The following is a description of a gene set: All-trans retinoic acid (RA) induces transforming growth factor beta (TGF-beta)-dependent autocrine growth of mouse embryonic fibroblasts (MEFs). We have used chromatin immunoprecipitation to map 354 RA receptor (RAR) binding loci in MEFs, most of which were similarly occupied by the RAR alpha and RAR gamma receptors. Only a subset of the genes associated with these loci are regulated by RA, among which are several critical components of the TGF-beta pathway. We also show RAR binding to a novel series of target genes involved in cell cycle regulation, transformation, and metastasis, suggesting new pathways by which RA may regulate proliferation and cancer. Few of the RAR binding loci contained consensus direct-repeat (DR)-type elements. The majority comprised either degenerate DRs or no identifiable DRs but anomalously spaced half sites. Furthermore, we identify 462 RAR target loci in embryonic stem (ES) cells and show that their occupancy is cell type specific. Our results also show that differences in the chromatin landscape regulate the accessibility of a subset of more than 700 identified loci to RARs, thus modulating the repertoire of target genes that can be regulated and the biological effects of RA. from publication Delacroix L, Moutier E, Altobelli G, Legras S, Poch O, Choukrallah MA, Bertin I, Jost B, Davidson I (PMID 19884340) Genes bound by RARG and down-regulated by tretinoin (all-trans retinoic acid, ATRA) in MEF cells (embryonic fibroblast). studied in species Mus musculus Human Gene Set: DELACROIX_RAR_TARGETS_DN, and this is the list of marker genes: PLSCR1, GAS2, FIGN, EMP1, ECHDC3, FUBP1, OGN, TIMP3, AQP5, SNTB2, ZNF469, KITLG, CKB, CLNK, FSTL1, GJB5 (gap junction protein beta 5), NRP1, LSP1, TPM2, MRGPRF, FGFR2, UBE2C, CTBP2, PALMD, CCND1, H1-2